Given this list of marker genes SH3PXD2B, NCF2, NOXO1, NCF1, NCF1C, NCF1B, PDGFB, NOXA1, NCF4, SH3PXD2A, AGT, here is a description of the gene set: Human Gene Set: GOMF_SUPEROXIDE_GENERATING_NADPH_OXIDASE_ACTIVATOR_ACTIVITY species: Homo sapiens Binds to and increases the activity of the enzyme superoxide-generating NADPH oxidase.